The following is a description of a gene set: Genes up-regulated in macrophages with IL10 knockout in response to 10 min treatment by: LPS versus LPS and IL10. IL-10 regulates anti-inflammatory signaling via the activation of STAT3, which in turn controls the induction of a gene expression program whose products execute inhibitory effects on pro-inflammatory mediator production. Here we show that IL-10 induces the expression of an ETS family transcriptional repressor, ETV3 and a helicase family co-repressor, SBNO2 (Strawberry notch homolog 2) in mouse and human macrophages. IL-10-mediated induction of ETV3 and SBNO2 expression was dependent upon both STAT3, and co-stimulus through the TLR pathway. We also observed that ETV3 expression was strongly induced by the STAT3 pathway induced by IL-10 but not STAT3 signaling activated by IL-6, which cannot activate the anti-inflammatory signaling pathway. ETV3 and SBNO2 specifically repressed NF-kB-mediated transcription and can physically interact. Collectively our data suggest that ETV3 and SBNO2 are components of the pathways that contribute to the downstream anti-inflammatory effects of IL-10. We compared expression profiles of macrophages isolated from IL-10 -/- mice. Macrophages were treated with either LPS or LPS plus IL-10. Treatment times were 10, 20 and 30 minutes. from publication El Kasmi KC, Smith AM, Williams L, Neale G, Panopoulos AD, Watowich SS, Häcker H, Foxwell BM, Murray PJ (PMID 18025162) Human Gene Set: GSE9509_LPS_VS_LPS_AND_IL10_STIM_IL10_KO_MACROPHAGE_10MIN_UP species: Homo sapiens, and this is the list of marker genes: PLAUR, CMTR1, ETV3, TOR1AIP1, DHX58, S100A5, PML, KRT77, SOX4 (NCBI Gene Id 6659), DGKE, PATJ, MTMR3, SPOCK1, TULP2, CPEB2, SOCS3, MARCKS, RCAN1, PLCZ1, SEMA6D, HRH4, IGF1 (NCBI Gene Id 3479), ADORA2B, FGF2, TRIM26, PPP4R1, NEK2, SLC14A1, SMIM3, CCL4, CD14, ANGPTL2, MYOF, ASPH, ST3GAL4, RHOU, PTPN13 (NCBI Gene Id 5783), ARHGEF10, PRKD1, ALCAM, EBF1, PHLPP1, HLA-DQA1, SERPINB2, RHOJ, FOS, SAMD4A, CLEC6A, ECHDC3, ISG20, ST8SIA1, EPCIP, SORCS3, ZFAND5, DAB2, POU6F1, CPEB3, THEMIS2, EDNRB, TRAFD1, DAXX, TRAF3IP2, ARF4, FAAH, CCL2, FOXO1, CXCL3, MAP3K20, CXCL2, NOCT, TSLP, TBC1D1, FRMD6, CYTH1, QPCT, HIPK2, RNF19B, MT1E, PLSCR1, KLF4, PLCL2, EPPK1, CMPK2, GADD45G, IL2RA, CYP4F12, TRIB1, CDCP1, TBX3, PMP22, RASA4, TIAM1, THBS2, IFT140, BASP1, CHMP4B, FOXA3, PDGFC, EREG, SDCBP2, CD209, BMP2K, PRKCE, FGD6, NPNT, HOXB6, NFIL3, MRC1, ZBTB44, CILP2 (NCBI Gene Id 148113), EFHD1, PROX1, NDRG1, MT2A, EDN1, LIF, SPSB4, LRBA, BDKRB1, HS3ST3A1, NCAM1, ZC2HC1C, FIG4, LITAF, FOXP3, B3GALNT1 (NCBI Gene Id 8706), RIN2, TPST1, PIK3AP1, MTMR10, EVA1A, NPL, PLAGL1, TSPAN13, VOPP1 (VOPP1 WW domain binding protein), RBMS2, CKB, CDH6, EXOC6, TUBB6, NMB, LRATD1, PRICKLE1, EPB41L4A, FBXO4, IL11, BBOX1, POU2AF1, RABGEF1, PLPP3, REL, OGFR, F3, CLCN5, RHOH, STMN2, C6, CCL7, KCTD12, PKHD1L1 (PKHD1 like 1), CLDN10, GCNT2, SIPA1L2, TDRP, PTPN1, EZR, COL4A6, CCN1, GEM, IL10, OASL, UBE2H (ubiquitin conjugating enzyme E2 H), PTX3, ARID5A, FHL2, SOS1, UCP1, ILDR1, N4BP1, CCRL2, OLIG1, EPB41, CLEC4A, SAP30, SATB1, DACT1, BCL2L11, CD93, PHLDA1, WDR54, GPX6, MYO5C, PLAT, CLN3, SAV1, PDLIM1, ING2, EXT1, NLGN1